Given this list of marker genes Pgk1, Gpc1, Rpe, Lhpp, Taldo1, Rars1, Spag4, Pygb, Pkp2, Galk2, Dsc2, Vldlr, Eno2, Pfkp, Ppia, B4galt4, Fbp2, Ecd, Gpr87, Nsdhl, Gys2, Ankzf1, Agrn, Cth, Cldn3, Glce, Glrx, Copb2, Homer1, Vegfa, Srd5a3, Cacna1h, Ext1, Ang, Eno1b, Gclc, Bpnt1, Gne, Ier3, Met, Kif20a, B4galt2, Me1, Me2, Kif2a, Capn5, Chpf2, Dld, Gfus, Pgls, Agl, B3gnt3, Med24, Casp6, Txn1, Stmn1, Pmm2, Xylt2, Ugp2, Egfr, Nol3, B3galt6, Hax1, Lct, Irs2, Got2, Slc37a4, Idh1, Ddit4, Vcan, Rragd, Gmppa (NCBI Gene Id 69080), Pfkfb1, Stc2, Angptl4, Ndst3, Cd44, Polr3k, Gys1, B4galt7, Ldha, Pcx, Gpc3, Chpf, Zfp292, Ak4, Cog2 (component of oligomeric golgi complex 2), Tff3, Gusb, Cldn9, Slc25a13, Cyb5a, B3gat3, Ext2, Chst4, Sdc3 (NCBI Gene Id 20970), P4ha2, Plod1, Gale, Slc16a3, Cln6, Tpbg, Mif (macrophage migration inhibitory factor (glycosylation-inhibiting factor)), Chst5, Ak3, Ldhc, Abcb6 (ATP-binding cassette, sub-family B member 6), Isg20, Adora2b, Slc25a10, Pam, Hs2st1, Mdh1, Aurka, Qsox1, Akr1a1, Pdk3, Mertk, Depdc1a, Gmppb, Sdhc, Aldoa, Sox9, Miox, Fut8, Pgm2, Plod2, Hk2, Cxcr4, Col5a1, Hdlbp, Dcn (decorin), Sdc2, Elf3, Egln3, Sdc1, Tpi1, Phka2, Chst12, Aldh7a1, Efna3, Lhx9, Slc35a3, Aldh9a1, Pgam1, Rbck1, Artn, Ndufv3, Pgam2, Ppp2cb, Nasp, Kdelr3, Mpi, Bik (BCL2-interacting killer), Got1, Tpst1, Stc1, Tktl1, Hspa5, Gfpt1, Prps1, Tgfa, Cdk1, Pygl, Gapdhs, Dpysl4, Sap30, Cited2, Aldob, Psmc4, Alg1 (NCBI Gene Id 208211), Sod1, Tgfbi, G6pdx, Fkbp4, Ppfia4, Nt5e, Ero1a, Mxi1, Chst2, Chst1, Galk1, Gpc4, Pkm, B4galt1 (UDP-Gal:betaGlcNAc beta 1,4- galactosyltransferase, polypeptide 1), B3gat1, Fam162a, Paxip1 (PAX interacting (with transcription-activation domain) protein 1), Cenpa, Mdh2, Il13ra1, Nanp, Igfbp3, Gnpda1, Gal3st1, Arpp19, P4ha1, Idua, Hmmr, Hs6st2, here is a description of the gene set: Mouse genes annotated to HALLMARK_GLYCOLYSIS based on orthology mappings provided by the Alliance Genome Consortium from publication Howe DG, Blake JA, Bradford YM, Bult CJ, Calvi BR, Engel SR, Kadin JA, Kaufman TC, Kishore R, Laulederkind SJF, Lewis SE, Moxon SAT, Richardson JE, Smith C (PMID 30224793) Mouse Gene Set: HALLMARK_GLYCOLYSIS species: Mus musculus